The following is a description of a gene set: An increased concentration of cholesterol in the blood. Human Gene Set: HP_HYPERCHOLESTEROLEMIA Hypercholesterolemia species: Homo sapiens, and this is the list of marker genes: PHKG2, SLC25A13, MKRN3, MEF2A, GHR, IRF5, COG4, TMEM199, SNORD116-1, ABCG8, RTL1, DIO1, STX5, TBL1X, LMNA, RSPO1, CAVIN1, PYGL, CCDC115, CEP19, LDLRAP1, IFT172, IQSEC2, SPIB, MYO5B, PPARG, APOB, CREB3L3, SNORD115-1 (small nucleolar RNA, C/D box 115-1), SLC7A7, ABCB4, MMEL1, PHKB, LPL, TBCK, PWAR1, APOC2, GALK1, PCSK9, PWRN1, NPHS1, TNFSF15, FLII, DYRK1B, HERC2, PIK3R5, JAG1, DGAT1, SLC25A36, ATP6AP1 (ATPase H+ transporting accessory protein 1), LDLR, NUP107, IL12RB1, MEG3, FOS, APTX, APOE, TNPO3, AGPAT2, TDP1, NPAP1, IL12A, POU2AF1, MAGEL2, KIF12, CYP7A1, ABCG5, IFT56, PNKP (NCBI Gene Id 11284), DLK1, CAV1, TTPA, ALB, SLC37A4, PHKA2, LIPA, OCRL (OCRL inositol polyphosphate-5-phosphatase), DEAF1, RAI1, SETX, TSHB, LIPC, CAV3, BSCL2